Given this list of marker genes LCN9, LCN12, SLC27A1, SLC27A6, LCN1, LCN15, SLC27A4, APOD, here is a description of the gene set: species: Homo sapiens Human Gene Set: REACTOME_TRANSPORT_OF_FATTY_ACIDS Transport of fatty acids